Given this list of marker genes TESMIN, CHD1L (chromodomain helicase DNA binding protein 1 like), PFKFB3, TJP2, MIOX, TNFRSF11B, FAM3D, HOMER2, GSTM1, BLOC1S6, ESRRB, COCH, CSN3, IL20, DERL1, SERPINB5, KITLG, POLR1B, PDE12, UBE2K, ALB, SELENOF, SLC12A2, FABP4, SLC25A51, CTNNB1, TRAF1, MARCKSL1, SFMBT1, CDKN1A, AMFR, HSPA14, MFGE8, SERPINA1 (NCBI Gene Id 5265), HAS2, TMEM30B, NCKAP1, EXTL1, STRA6, TUBG2, CHST4, CD2AP, RFK, MFSD14B, KRT79, QSER1, RLIG1, SERPINA10, CEMIP, COMMD9, RPS18, USP45, SLC24A3, ATP11B, C3, S100A5, SLC15A5, ACTL7A, ATP1B3, MYOZ2, DIO1, PLA2G2D, BNIPL, DSC3, ACHE, IGF1R, BIRC2, OGFRL1, EHD3, MMD, TRH, SUSD2, TRIM3, CELSR3, KIF16B (kinesin family member 16B), MT2A, ABHD18 (NCBI Gene Id 80167), MCHR1, OXR1, FNDC7, METTL9, PPL, NF1, SLC6A20, LRAT, OLIG2, RPS6KL1, KCND3, BEX1, NOTCH4, FBP2, CCSER2, ANKH, FCAMR (NCBI Gene Id 83953), BEST2, USP33, GTF2IRD1, MISP (NCBI Gene Id 126353), LIMCH1, NGFR (NCBI Gene Id 4804), SPSB4, GBA1, ANXA1 (annexin A1), UBD, MYH4, SFMBT2, NSMCE3, MORC4, MNAT1, RRP8, SLC5A7, SYAP1, PATZ1, KLHL24 (NCBI Gene Id 79965), DNAI4, AP3S1, CCL19, GLP1R, CYTH3, THRB (thyroid hormone receptor beta), CSN2, DTX1 (NCBI Gene Id 1840), FADS2, IL7R, GGPS1, TFG, PIAS2, GPX6, NDP, ARHGAP24, CFB, ST6GALNAC2, CRTAP, RYR3, NEXMIF, BLCAP, DGUOK, PPM1B, MSC, PEX5L, RASA2, PRDX6, HES3, BCS1L, FAM184B, SRSF10, CRIP3, ENPP2, MYL12B, KCNA3, PTX3, GPALPP1, ITIH5, CLDN19, CCDC186, VAV3, LXN, RDH10, TMEM54, CLEC5A, BST1, BARHL1, PRSS12, NIPSNAP3A, ADAM9, CDH11, FAM13B, NKAPL, PGM1, RND3, DEPTOR, APEX1, DCLK1, GDA, NECAB3, DHX9, GSR, GSTA3, RETREG2 (reticulophagy regulator family member 2), MAVS, ZBTB1, CLDN6, TCF7, PSMD14, PFN2, GJA1, KIF1B, SLC16A3, EEPD1, MYT1, SNCA, MICAL2, CCDC88A, NAPB (NCBI Gene Id 63908), RPUSD1, ZWINT, SLC34A1, RAB20, CSF2RB, EXOSC4, here is a description of the gene set: studied in species Homo sapiens Human Gene Set: GSE23505_UNTREATED_VS_4DAY_IL6_IL1_TREATED_CD4_TCELL_DN CD4+ T cells that selectively produce interleukin (IL)-17, are critical for host defense and autoimmunity1-4. Crucial for T helper17 (Th17) cells in vivo5,6, IL-23 has been thought to be incapable of driving initial differentiation. Rather, IL-6 and transforming growth factor (TGF)-β1 have been argued to be the factors responsible for initiating specification7-10. Herein, we show that Th17 differentiation occurs in the absence of TGF-β signaling. Neither IL-6 nor IL-23 alone efficiently generated Th17 cells; however, these cytokines in combination with IL-1β effectively induced IL-17 production in naïve precursors, independently of TGF-β. Epigenetic modification of the Il17a/Il17f and Rorc promoters proceeded without TGF-β1, allowing the generation of cells that co-expressed Rorγt and T-bet. T-bet+Rorγt+ Th17 cells are generated in vivo during experimental allergic encephalomyelitis (EAE), and adoptively transferred Th17 cells generated with IL-23 in the absence of TGF-β1 were more pathogenic in this experimental disease. These data suggest a new model for Th17 differentiation. Consistent with genetic data linking the IL23R with autoimmunity, our findings re-emphasize the role of IL-23 and therefore have important implications for the development of new therapies. from publication Ghoreschi K, Laurence A, Yang XP, Tato CM, McGeachy MJ, Konkel JE, Ramos HL, Wei L, Davidson TS, Bouladoux N, Grainger JR, Chen Q, Kanno Y, Watford WT, Sun HW, Eberl G, Shevach EM, Belkaid Y, Cua DJ, Chen W, O'Shea JJ (PMID 20962846) Genes down-regulated in CD4 T cells: untreated versus IL1B and IL6.